The following is a description of a gene set: Mouse Gene Set: GOCC_MRE11_COMPLEX Trimeric protein complex that possesses endonuclease activity; involved in meiotic recombination, DNA repair and checkpoint signaling. In Saccharomyces cerevisiae, the complex comprises Mre11p, Rad50p, and Xrs2p; complexes identified in other species generally contain proteins orthologous to the Saccharomyces cerevisiae proteins. species: Mus musculus, and this is the list of marker genes: Mre11a, Rad50, Sp100, Nbn, Mrnip